The following is a description of a gene set: Any process that increases the rate or frequency of phosphatase activity. Phosphatases catalyze the hydrolysis of phosphoric monoesters, releasing inorganic phosphate. Mouse Gene Set: GOBP_POSITIVE_REGULATION_OF_PHOSPHATASE_ACTIVITY species: Mus musculus, and this is the list of marker genes: Ripk3, Rock1, Mef2c, Mtmr9, Gpld1, Ifng, Chp2, Bmp2, Npnt, Ppargc1b, Plek